Given this list of marker genes NUFIP2, ISL2, RACGAP1, ASF1A, NUP85, FOXL1 (NCBI Gene Id 2300), DAZAP1, MBTD1, PPARG, FAXDC2, PSMB6, here is a description of the gene set: Genes containing one or more binding sites for (ZNF626) in their promoter regions (TSS -1000,+100 bp) as identified by GTRD version 20.06 ChIP-seq harmonization. from publication Yevshin I, Sharipov R, Kolmykov S, Kondrakhin Y, Kolpakov F (PMID 30445619) species: Homo sapiens Human Gene Set: ZNF626_TARGET_GENES